Given this list of marker genes H2bc27, H2ac20, H4c11 (H4 clustered histone 11), H4c14, H4c18, H2ac7, H4c3, H2ac11, H3c7, H4c9, H2ac23, H3f3a, H2ac4, Rbbp7 (retinoblastoma binding protein 7, chromatin remodeling factor), H2bc12, Ezh2, H2bc22, H2ac1, Zmym2, H2bc15, H2bc9, H3c10, Kdm1a, Twist1, H2ac6, H2ac13, H3c8, H2ac24, H4c2, Smarca4, Rbbp4, H4c8, H4c6, H3c2, H3c13, H2ac19, H2az2, H2bc11, H2bc1, H3c1, H2ac12, H2bc13, H4c17, H4c12, H3c11, H2bc7, H3c4, H4c1, H2ac8, H2ac22, H2ac10, H3c6, H4c4, H2bc8, Dnttip1, H2bc3 (NCBI Gene Id 319178), H2ax, H2ac15, H3c3, H3c15, here is a description of the gene set: studied in species Mus musculus This event has been computationally inferred from an event that has been demonstrated in another species.<p>The inference is based on the homology mapping from PANTHER. Briefly, reactions for which all involved PhysicalEntities (in input, output and catalyst) have a mapped orthologue/paralogue (for complexes at least 75% of components must have a mapping) are inferred to the other species. Reactome Pathway: Regulation of CDH1 Gene Transcription part of: Regulation of CDH1 Expression and Function electronically inferred by orthology from the curated human pathway